Given this list of marker genes Gm5849, Vps37b, S100pbp, Nrxn1, Anxa3 (NCBI Gene Id 11745), Tnnt3, Snx27, Masp1, Kcnip3, Chp1, Pef1, Myo5a, Nsmf, Wfs1, S100a13, Cd209b (CD209b antigen), Fcnb, A2m, S100b, Mbl1, S100a2, Anxa11, S100a6, Selp, S100a11-ps, Grin2a, Anxa7, Stx2, Sntn, Slc9a1, S100z, Clxn, Mmp13, Slc24a4, Tsg101, Calm2, S100a1, Mgp, Cd209a (CD209a antigen), Syn2, S100a3, S100a14, Cln3, Vps37c, S100g, Syt8, Nos1, Anxa1, S100a7l2, Anxa2, Pdcd6ip, Ddx5, Tnnc1, Hnrnpm, Sec31a, Myo1d, Syt6, Plscr3, Mbl2, Anxa4 (NCBI Gene Id 269772), Stx1a, Casq2, Syt1, Pdcd6, S100a9, Tnni3, Masp2, Grm7, Anxa6, Vamp2, Snap25, Cplx2, Rbm22, Spaca9, Cd177, S100a4, Lrp8, S100a16, Calm1, Stmn2 (stathmin-like 2), Cabp1, Rac3, S100a5, S100a8, S100a10, Vldlr, Crnn, Syn1, Calm3, Grm4, S100a11, Cpne3, S100a7a, here is a description of the gene set: Binding to a protein or protein complex in the presence of calcium. Mouse Gene Set: GOMF_CALCIUM_DEPENDENT_PROTEIN_BINDING studied in species Mus musculus